Given this list of marker genes ZNRF1, PDE3B, SPTBN1, DAPL1, TBC1D4, GPD2, here is a description of the gene set: Transcription factor Foxp3 (forkhead box P3), restricted in its expression to a specialized regulatory CD4+ T-cell subset (T(R)) with a dedicated suppressor function, controls T(R) lineage development. In humans and mice, Foxp3 deficiency results in a paucity of T(R) cells and a fatal breach in immunological tolerance, causing highly aggressive multi-organ autoimmune pathology. Here, through genome-wide analysis combining chromatin immunoprecipitation with mouse genome tiling array profiling, we identify Foxp3 binding regions for approximately genes and for an intergenically encoded microRNA. We find that a large number of Foxp3-bound genes are up- or downregulated in Foxp3+ T cells, suggesting that Foxp3 acts as both a transcriptional activator and repressor. Foxp3-mediated regulation unique to the thymus affects, among others, genes encoding nuclear factors that control gene expression and chromatin remodelling. In contrast, Foxp3 target genes shared by the thymic and peripheral T(R) cells encode primarily plasma membrane proteins, as well as cell signalling proteins. Together, our studies suggest that distinct transcriptional sub-programmes implemented by Foxp3 establish T(R) lineage during differentiation and its proliferative and functional competence in the periphery. Genes with promoters bound by FOXP3 and which are down-regulated both in developing (located in the thymus) and mature (from peripheral blood) regulatory CD4+ T lymphocytes. from publication Zheng Y, Josefowicz SZ, Kas A, Chu TT, Gavin MA, Rudensky AY (PMID 17237761) Human Gene Set: ZHENG_FOXP3_TARGETS_DN species: Mus musculus